The following is a description of a gene set: studied in species Homo sapiens Genes up-regulated in comparison of macrophages exposed to 50 worms/well B. malayi versus those exposed to 5 worms/well B. malayi. Human Gene Set: GSE360_HIGH_VS_LOW_DOSE_B_MALAYI_MAC_UP Monocyte-derived dendritic cells (DC) and macrophages (MΦ) generated in vitro from the same individual blood donors were exposed to five different pathogens, and gene expression profiles were assessed by microarray analysis. Responses to Mycobacterium tuberculosis and to phylogenetically distinct protozoan (Leishmania major, L. donovani, Toxoplasma gondii) and helminth (Brugia malayi) parasites were examined, each of which produces chronic infections in humans yet vary considerably in the nature of the immune responses they trigger. from publication Chaussabel D, Semnani RT, McDowell MA, Sacks D, Sher A, Nutman TB (PMID 12663451), and this is the list of marker genes: ABCB7, MAN2B2, SVEP1, ARHGDIB, TSPAN31, MYCL, ZNF207, ERCC4, LSAMP, BBS9, TNK2, CP, NR1H2, TCP1, M6PR (NCBI Gene Id 4074), MSH3, KATNB1, C6orf47, PUM3, PFKFB1, SHBG, NOP16, PLEKHB1, IGSF6, ATMIN, SPC25, DBP, QSOX1, XPNPEP1, ATP6V0E1, HSPA6 (NCBI Gene Id 3310), CDH5, CRABP2, SCN4A, SPA17, PSMC3, ARAF, PHF24, TRIM21, H2AZ1, MAPKBP1, PIAS4, PC, ZBTB48, COL16A1, KAT6A, RELN, IDUA, AIMP2, PRKCB, PARK7, ATP5MC1, DNAJC16, RBM17, H2BC7, ATP5MF, MTHFS, TLE2, PMP22, ORC4, CCNB1, RAB3GAP1, RALB, PLIN2, SCAMP3, PFDN1, MYO1F, ABCB1, PCM1, CARD10, IFI16, IL1RN, ALDH1L1, GOLGB1, DNAJC8, NADK, ZNF711, PSMD8, ZNF263, HMGCS2, GNPAT, STIP1, GALK2, UCHL1, CD6, H2BC10, BRINP1, BMP6, HTT, KHSRP, ACRV1, OXSR1, FNBP4, GTF2B, CLTB, PPP1R10, CXCR2, GCDH, CYP51A1, LCE2B, MPHOSPH8, DIP2C, SSNA1, ADCY3, MX2, PSMC3IP, SKAP2, RGS16, IRF7, PCSK5, BANF1, PPBPP2, COX6A1, PRRC2B, KMT2D, NFKB1, PPIF, PSMB6, ANK3, TRIM44, CD163, SRPX2, SERPINB1, NBR1, DAXX, RASSF2, ADCYAP1, BAZ1B, TALDO1, USP5, MSMB, EIF3G, ATF6, SMARCC1, PCDHB11, UQCRC1, PGD, ERCC2, ERP29, GABRB2, PTPN9, PIK3R3, FBLN1, CCS, SIPA1, HARS2, RNF14, GNS, TAF11, HSD17B10, BRAP, UBE2N, MCF2, HSBP1, FKBP4, FCN1, GRK3, MBOAT7, PLCG1, CAP1, KCNB2, VAMP2, FXR2, CHMP2A, ZHX2, ZHX3, PLCG2, ADM, SRRD, SYN3, DDX3X, FAM216A, MUC4, UBA1, NCBP1, MYRIP, MAGEB2, RABGGTA, GUSBP3, UBE2V2, EIF4A1, GAS6, FAM168B, CXCR4, SLC43A1, NUP188, ALDH1B1, DIAPH1, KIF3C, MISP, NDUFS1, BAAT, ACTN1, ATP2A2, PAEP, ATOX1, ICAM3, SAP18, CROT, CYP2C18